Given this list of marker genes HDAC9, NLRP9, TNFAIP8L3, CLEC4C (NCBI Gene Id 63328), ZNF774, PIP5K1B, LGI2 (leucine rich repeat LGI family member 2), ALLC, CYB5R3, BIRC5, S100A10, MYF6, EFS, FBXO39 (NCBI Gene Id 162517), GOLGA7B, SMARCA4, RFPL2, SLC25A17, SLCO5A1, RAB38, CALM3, MTMR1, FSTL5, TMPRSS2 (NCBI Gene Id 7113), GPC3, GPC6, VIM, ABLIM3, MRGPRF, DEF8, GDA, MMP28, CA14, DHX30, CSN3, UCN2, RP9P, VNN1, APCDD1L, SNHG32, DPCD, MMP27, INPP5A, OR7G2, NCK2, SCIN, PRSS23, FGF18, PRKN, OR2H2, CTSH, ATP6AP1-DT, CLUHP3, PNPLA6, ZNRF1, DOCK3, PDE4D, IGFBP2, SERPINB5, MELTF (NCBI Gene Id 90031), VLDLR, ZDHHC7, DNAJC12, SQLE, ACTG2, NPBWR2, ITGB3, INTS5, CSTB (cystatin B), TMEM171, NEDD9, LINC02210, FBXW9, AMZ1, BCAR1, KRT10, COL6A1, MINDY1, OR6K3, KRTAP10-9, CABP1, RAB11FIP1, HAO1, SLC25A29, MMP11, FERMT2, SIGLEC15, ITGB1, DNAI3, TMEM14C, ZCCHC18, ATP10B (NCBI Gene Id 80225), REM1, FLNB, BTG1, CACNG2, STARD9, PLA2G15, LGALS1, NEGR1, PSD3, CYP4F22, RAB33A, PLSCR3, BCAP31, CRYBB2P1, SOHLH2, UTS2B, FARP1, NCKAP5L, SLC6A7, PLP2, DNER, WDR27, CD101, TBC1D8, TCF3, ADGRL1, ZNF236, GLT8D1, ITGA3, HSD11B1L, SRM, TPST1, RPS28, MIR138-2, CXCR5, HYAL1, RASAL1, HARS2, PABPC4, NAV2, FAM83D, PODXL, C12orf54, SDK1, GNB1, GOLGA6L2, ITGAX, UBTD1, COL6A2, ATP5F1A, PLEKHB2, TNFRSF9, MCEE, WFS1, CCR4 (C-C motif chemokine receptor 4), STRIP2, ZNF250, COL4A2, APCDD1, ABO, PC, CKAP4, SERINC2, SLAMF9, NRF1, CBX1, CACNG5, SLC2A5, INTU, TNFSF14, PLXND1 (NCBI Gene Id 23652), JUP, NAA16, TMEM98, GREM2, SLC39A4, AGBL5, HDAC10, CAMTA2, SPTBN1, ELOVL5, SP3P, SPARC, MAP1A, ZNF697, SLC16A10, PDZD4, OR2L2, HAGH, HS6ST1, LRP1, DEXI, PHLDA3, TMEM44, ACADVL, CPEB1, TRAP1, DDR2, NOL4L-DT, SYTL2, GBE1, LINC00479, NCBP2L, here is a description of the gene set: from publication Samstein RM, Arvey A, Josefowicz SZ, Peng X, Reynolds A, Sandstrom R, Neph S, Sabo P, Kim JM, Liao W, Li MO, Leslie C, Stamatoyannopoulos JA, Rudensky AY (PMID 23021222) Human Gene Set: GSE40685_NAIVE_CD4_TCELL_VS_FOXP3_KO_TREG_PRECURSOR_DN species: Homo sapiens Regulatory T (Treg) cells, whose identity and function are defined by the transcription factor Foxp3, are indispensable for immune homeostasis. It is unclear whether Foxp3 exerts its Treg lineage specification function through active modification of the chromatin landscape and establishment of new enhancers or by exploiting a pre-existing enhancer landscape. Analysis of the chromatin accessibility of Foxp3-bound enhancers in Treg and Foxp3-negative T cells showed that Foxp3 was bound overwhelmingly to pre-accessible enhancers occupied by its cofactors in precursor cells or a structurally related predecessor. Furthermore, the bulk of Foxp3-bound Treg cell enhancers inaccessible in Foxp3- CD4+ cells became accessible upon T cell receptor activation prior to Foxp3 expression with only a small subset associated with several functionally important genes being exclusively Treg cell-specific. Thus, in a late cellular differentiation process Foxp3 defines Treg cell functionality in an “opportunistic” manner by largely exploiting the preformed enhancer network instead of establishing a new enhancer landscape. Genes down-regulated in CD4: naïve versus FOXP3 knockout T reg precursors.